The following is a description of a gene set: species: Homo sapiens PDGFR-beta pathway Human Gene Set: WP_PDGFRBETA_PATHWAY, and this is the list of marker genes: JAK1 (NCBI Gene Id 3716), GRB2, STAT5A, FOS, PRKCB, ELK1, PIK3CA, HRAS, PDGFRB, MAPK3, SOS1, PLCG1, RASA1, SHC1, STAT1 (NCBI Gene Id 6772), MAP2K1, PIK3R1, JUN, STAT6, JAK2, SRF, STAT3, EIF2AK2, RAF1, MAP3K1, MAP2K4, MAPK8, STAT5B, PRKCA